The following is a description of a gene set: Reactome Pathway: Class I MHC mediated antigen processing & presentation studied in species Homo sapiens part of: Adaptive Immune System Major histocompatibility complex (MHC) class I molecules play an important role in cell mediated immunity by reporting on intracellular events such as viral infection, the presence of intracellular bacteria or tumor-associated antigens. They bind peptide fragments of these proteins and presenting them to CD8+ T cells at the cell surface. This enables cytotoxic T cells to identify and eliminate cells that are synthesizing abnormal or foreign proteins. MHC class I is a trimeric complex composed of a polymorphic heavy chain (HC or alpha chain) and an invariable light chain, known as beta2-microglobulin (B2M) plus an 8-10 residue peptide ligand. Represented here are the events in the biosynthesis of MHC class I molecules, including generation of antigenic peptides by the ubiquitin/26S-proteasome system, delivery of these peptides to the endoplasmic reticulum (ER), loading of peptides to MHC class I molecules and display of MHC class I complexes on the cell surface., and this is the list of marker genes: UBA6, KCTD6, HLA-F, SEC61G, NCF2, FBXO40, UBE2R2, ASB18, UBE2Q2, ANAPC13, UBE2E2, TRIM71, RNF213, RNF19A, UBA7, UBE2E1, UBR4, TLR4, TRAF7, PSMD14, HECTD3, KLHL2, FBXW8, KLHL3, HERC2, UBE3C, UBE2J1, 8, NEDD4, SIAH1, TRIP12, FBXL12, FBXW5, UBE2U, CD36, ADRM1, FBXO6, UBE2G1, CDC27, UBC, CYBB, S100A9, ASB17, FBXO10, FBXL18, STUB1, FBXO17, PIK3R4, TRIM36, FGA, PSMA1, SEC23A, FBXL20, TRIM4 (tripartite motif containing 4), IKBKG, MKRN1, RNF126, UBE4A, SEC61B, FBXO41, HERC5, PSME1, CUL1, UBE2M, TRIM39, LRRC41, UBE2V1, HERC3, TRIM41, PSMA7, PSMB3, ASB16, CYBA, FBXW2, CUL3, ASB9, LTN1, SOCS3, KEAP1, ITGAV, CUL7, ASB1, SEC24C, SPSB1, FBXO31, UBE2A, SKP2, ERAP2, FBXW9, TAPBP, FBXW12, SEC61A2, UBE2W, UBE2G2, HERC6, FBXW10, PSMD1, SNAP23, TLR2, KLHL25, RNF19B, RBBP6, UBE2O, UBE2E3, ITGB5, ZBTB16, FBXL14, UBE2D1, UBE2J2, KLHL9, VAMP8, HECTD2, SEC22B, ASB3, CCNF, SKP1, PJA1, LY96, KLHL41, CD207, TRIM9 (tripartite motif containing 9), ASB2, FCGR1A, ASB13, ASB12, RNF111, CTSS, KCTD7 (potassium channel tetramerization domain containing 7), PSMB10, CDC26, SMURF2, KLHL5, NEDD4L, CDC34 (cell division cycle 34, ubiqiutin conjugating enzyme), HECW2, PSMB5, TRAIP, KLHL13, MYLIP, CDC23, CALR, FGG, FBXL8, WWP1, HECTD1, LMO7, ITCH, ERAP1, BTBD6, TRIM11, ASB4, CBLL2, PSMB9, UBE3A, FBXO4, TIRAP, MIB2, FBXL22, FBXW4, ASB14, PRKN, PSME2, UBE2D3, ELOB, HERC4, BECN1, PSMB7, SH3RF1, VHL, TRIM21, MGRN1, FBXL21P, RNF14, KLHL21, SEM1, RNF6, ELOC, FZR1, WSB1, UBE2Z, B2M, UBE2Q1, RNF115, SPSB4, PIK3C3, PSMD11, ASB6, AREL1, UBE2K, FBXO7, NCF1, HLA-H, SMURF1, UBE2F, BLMH, NPEPPS, ASB7, SOCS1, ASB5, PSMA3, SAR1B, TPP2, KBTBD6, RNF25 (NCBI Gene Id 79103), CTSV, RNF144B, FCGR1BP, ASB8, BTRC, FBXO15, BTBD1, RNF138, HUWE1, RNF34, FBXO21, STX4, UBAC1 (NCBI Gene Id 51408), ANAPC2, FBXO30, UBA1, UBE2C, CDC20, ARIH2, PSMB1, RNF114, RPS27A, UBOX5, ANAPC4, KBTBD8, UBB, TRIM50, KBTBD13, SEC24D, MRC1, UBE2L6, PSMD13, DTX3L, SEC24A, UFL1 (UFM1 specific ligase 1), HMGB1, CBLB, PSMA5, RNF123, FBXO44, RBX1, SEC31A, HERC1, FBXO2, TRIM63, FBXO32, TAP1, PSMD2, LNX1, FBXL19, SPSB2, KLHL22, PSMC5, UBE3D, SEC24B, UBE2D2, LNPEP, HLA-B, ANAPC10, ATG14, HLA-G, ASB10, PSMD8, KBTBD7, KLHL20, SEC13, RNF41, PJA2, FBXL15, PSMA4, PSMD3, CUL2, HLA-C, FBXL7, FBXO9, ATG7, ANAPC7, ASB15, TRIM69, RLIM, PSMC6, KLHL11, RNF4, CUL5, UBE2S, FBXO11, HLA-E, UBE2L3, IKBKB, PSMC2, UBE2H, CANX, PSMB6, S100A8 (S100 calcium binding protein A8), UBA5, VAMP3, FBXL16, NCF4, PSMC4, UBA3, MEX3C, PSMB8, RBCK1, BTK, RNF217, PDIA3, FGB, TRIM37, UNKL, PSMD6, GAN, porB, FBXW7, FBXL5 (F-box and leucine rich repeat protein 5), LRR1, UBE2N, CDC16, FBXO27, FBXL3, PSMD12, TRIM32, SIAH2, UBE2V2, PSMD7 (NCBI Gene Id 5713), UBE3B, RNF130, UBA52, ASB11, GLMN, mip, LRSAM1, HSPA5, CTSL, ANAPC11, FBXO22, FBXL13, PSMC1, TLR6, S100A1, DET1, PSMB2, KLHL42, RNF7, ZNRF1, RCHY1, FBXW11, ANAPC5, DZIP3, CHUK, TAP2, UBR1, PSMA6, PSMB4, UBE2D4, RNF220, PSMC3, HACE1, DCAF1, ZNRF2, UBR2 (NCBI Gene Id 255838), UBE2B, PSMA2, RNF182, THOP1, MRC2, SEC61A1, HLA-A, BCAP31, ANAPC1, FBXL4, TLR1, LONRF1, CD14, MYD88